The following is a description of a gene set: part of: Fatty acid metabolism Reactome Pathway: Carnitine shuttle electronically inferred by orthology from the curated human pathway studied in species Mus musculus This event has been computationally inferred from an event that has been demonstrated in another species.<p>The inference is based on the homology mapping from PANTHER. Briefly, reactions for which all involved PhysicalEntities (in input, output and catalyst) have a mapped orthologue/paralogue (for complexes at least 75% of components must have a mapping) are inferred to the other species., and this is the list of marker genes: Cpt1b, Thrsp, Slc22a5, Mid1ip1, Cpt2